Given this list of marker genes FBXW11, BLOC1S3, KIF3B, AP3M2, RASGRP1, RAB1A, BLOC1S2, FYCO1, NDE1, SNAPIN, CDR2L, KIF5A, AP3S1, AP3S2, KIF16B, AP3M1, TRAK2, AP3B1, MAP2, HAP1, DYNC1I1, BICDL2, TRIM46, BICDL1, DTNBP1, KIF5B, BORCS5, KIF1B, KIFAP3, MAP2K1, STK11, PAFAH1B1 (NCBI Gene Id 5048), CLN3, KIF1C, AP3B2, KIF28P, BLOC1S1, SPG11, HTT, KIF3A, BLOC1S6, TRAK1, NDEL1, SYBU, BLOC1S5, AP3D1, KIF13A, BLOC1S4, KIF1A, here is a description of the gene set: species: Homo sapiens Human Gene Set: GOBP_VESICLE_TRANSPORT_ALONG_MICROTUBULE The directed movement of a vesicle along a microtubule, mediated by motor proteins. This process begins with the attachment of a vesicle to a microtubule, and ends when the vesicle reaches its final destination.